Given this list of marker genes MATN3, TRPV4, TRAPPC2, SMAD3, ASPN (asporin), here is a description of the gene set: Osteoarthritis of the small joints of the hand species: Homo sapiens Human Gene Set: HP_OSTEOARTHRITIS_OF_THE_SMALL_JOINTS_OF_THE_HAND